The following is a description of a gene set: Human Gene Set: GOBP_MEMBRANE_FUSION species: Homo sapiens The membrane organization process that joins two lipid bilayers to form a single membrane., and this is the list of marker genes: SPATA46, TMEM175, USO1, NOX5, STXBP1, DOC2A, SNCA, IZUMO1, LYZL6, VPS39 (VPS39 subunit of HOPS complex), NAPG, RAB8A, RAB4B, CPLX1, ANKFY1, TRARG1, DCSTAMP, SNAP23, EEA1, CHMP1A, GCA, HACE1, TBC1D4, CH25H, STX19, VPS18, PIP4K2A, MYMX, STXBP6, NKD2 (NKD inhibitor of WNT signaling pathway 2), CHMP2B, SYT2, PIP4K2B, GOSR2, CHMP4A, CHMP3, DCST1, PIKFYVE, SYT5, ATP13A2, GLIPR1L1, NSFL1C, NECTIN2, SYT4, RAB3A, CLTRN, KIAA0319L, SYT9 (synaptotagmin 9), CPLX2, VPS33A, SPACA6, GOSR1, TMEM95, CHMP5, CAV2, CPLANE2, SOX30, FOLR1, VTI1B, SEC22B, STX11, HUWE1, TSNARE1, BNIP1, RABEP1, SNAP47, SPACA5, SYT1, TOM1, SPACA5B, VAMP3, CHMP4B, CD9, ANXA7, GAS6, RAB14, OTOF, BET1L, FREY1, SPESP1, VPS16, VIPAS39, DOC2B, CPLX3, CHMP4C, OPA1, NSF, TPST2, STX6, STX16, IRAG2, CPLX4, CHMP1B (NCBI Gene Id 57132), ZNRF2, LLCFC1, EQTN (equatorin), VAMP2, SNAPIN, RUFY1, DCST2, C16orf92, DIAPH3, LYZL4, SPPL2C, DPP4, RABIF, SPAM1, SYT3, YKT6, ATL2, RPH3A, STX5, CHMP2A, CHMP6, RAB2A, RUBCNL, VPS4A, YIPF4, VAV3, ANXA2, STX1B, CLN3, TGFBRAP1, YIPF7, C2CD5, ATL3 (NCBI Gene Id 283241), SYT13, VAPA, VPS8, STX12, SPHK1, STX3, SEC22A, STX17, ARL8B, ANKRD27, VPS33B, VAMP1, CORO1A, IZUMO1R, YIPF5 (NCBI Gene Id 81555), USE1, BLOC1S6, VCPIP1, MYMK, STX18, RUFY4, STX7, SLAMF1, ADAM2, UBXN2A (NCBI Gene Id 165324), ERC2, PLA2G5, LRRK2, RIMS1, UBXN2B, STX10, VTI1A, RAB20 (NCBI Gene Id 55647), SNAP25, WDR54, NAPA, RAB7A, SYT11, PLEKHM1, CRISP1, SNAP29, STX2 (NCBI Gene Id 6808, syntaxin 2), ACE2, VAMP8, VPS11, SYT7, CHMP7, RPH3AL, ATL1, C9orf72, TIE1, CHP1, RAB34, SPG11 (SPG11 vesicle trafficking associated, spatacsin), VAMP7, ANXA1, STX1A, GRIK5, SEPTIN8, ZNRF1, SPACA3, VAMP4, BET1, STX8, CTSL, ROPN1B, RAB39A, RAB7B, SAMD9, PRRT2, STX4, SYT8, FOLR3, VPS41 (VPS41 subunit of HOPS complex), UVRAG, SERPINA5, FOLR2